Given this list of marker genes ITM2A, PSD3, DYNLT5, ARMCX6, ABCC9, AMIGO1, TOX3, EDARADD, CSGALNACT1, CCL24, IFT81, ETNK2, CHRNA7, BCHE, CEP78, F2, EVI5L, C1S, SATB1, ART4 (ADP-ribosyltransferase 4 (inactive) (Dombrock blood group)), GMPR, CHL1, CBX1, MIR99AHG, CROCC, DDX39B, ZNF354B, MXRA7, CCR9, GPR162, NOTCH3, BCL2L14, ADGRA3, HIF3A, BLOC1S4 (biogenesis of lysosomal organelles complex 1 subunit 4), ABHD17C, LMAN1L, TIGD3, SNX15, MCAM, TMEM151B, TTC23L, COQ4 (NCBI Gene Id 51117), HAS2, NLRP6, SMCO1, CLDN4, MARCKS, HS2ST1, ARX, SOX12, CCDC61, GRHL3, ING1 (inhibitor of growth family member 1), IL34, PPT2, PTOV1, DUSP26, PKMYT1, ADM2, LDHB, MYBPC3, DLL4, ZNF286A, COL27A1, GSK3B, SPEF1, TNK2, PRRT1, KHDRBS1, CTTN, DYNC2I1, SMO, TUBB2B, ARMC12, NYAP1, PNMA5, VWCE (von Willebrand factor C and EGF domains), DHTKD1, CCDC175, CFAP157, UBE2E3, OSBPL1A, PLOD2 (NCBI Gene Id 5352), SNAI3, CLK3, DPP9, CTXN1, MXI1, TFPI2, RAB27B, NRG3, CNN3, BFSP2, STX6, FFAR2, SLC45A3, DUSP23, FAM184A, NKX2-4, KIF23, VSIG4, HHIPL2, ACVR2B (NCBI Gene Id 93), KCNS2, MBOAT2, CUEDC2, NMNAT1, TRIM11, SSPOP, LZTFL1, RBP7, TRIM63, CTNNA2, PALM, ULBP1, MEX3A, KPRP, ADGRG1, GINS1, TUBA1A, SPOCK3, TMEM255A (NCBI Gene Id 55026), IPO9, PTPRF, DMRT2, CRY1, SSBP2, ABCC2, TMEM45A, UTS2, SYNE3, CXADR, LCMT1, SYT7, TEKT2, GC, FLRT1, TDRD5, YBX1, MPP2, F13A1, S100A3, PURG, VWA3B, RND2, CBX3, PTPRK, IRAK1BP1, KCNE5 (potassium voltage-gated channel subfamily E regulatory subunit 5), AP3S1, SLC25A47, KRT84, UACA, ID1, ZNF385A, SLC43A1, APBB2, ACSM1, LIPF, CTC1, NEXMIF, CCDC159, SCN1B, IL1A, NEDD4, JMJD4, CRYGB, ATL2, ANK3, TMEM120B, CTDSPL, GPC1, FLT4, ABCC5, GOLM2, CBLN4, CBLC, SERPINA4, KALRN, TJAP1, CAMK2A, HACD1, KCNMB2, IFT56 (NCBI Gene Id 79989), BCORL1 (BCL6 corepressor like 1), CAMKK1, CAPN10, YPEL2, ASB2, CTNNBIP1, PADI4, TMTC3, STOX2, C1orf116, ALDH7A1, CCDC120, GBX2, ZDHHC14, C16orf87, here is a description of the gene set: After positive selection in the thymus, the newly generated single positive (SP) thymocytes are phenotypically and functionally immature and undergo apoptosis upon antigen stimulation. In the thymic medullary microenvironment, SP cells progressively acquire immunocompetence. Negative selection to remove autoreactive T cells also occur at this stage. We have defined four subsets of CD4 SP, namely, SP1, SP2, SP3, and SP4 that follow a functional maturation program and a sequential emergence during mouse ontogeny.We used microarray to detail the global programm of gene expression during the maturation of murine CD4 single positive thymocytes Human Gene Set: GSE30083_SP3_VS_SP4_THYMOCYTE_UP species: Homo sapiens from publication Teng F, Zhou Y, Jin R, Chen Y, Pei X, Liu Y, Dong J, Wang W, Pang X, Qian X, Chen WF, Zhang Y, Ge Q (PMID 22022412) Genes up-regulated in comparison of SP3 thymocytes versus SP4 thymocytes.